Given this list of marker genes Wnt1, Snx3, Wnt2b, Wnt3, Vps35, Wnt6, Wnt4 (NCBI Gene Id 22417), Wnt5b, Wnt8b, Wnt11, Vps26a, Tmed5 (transmembrane p24 trafficking protein 5), Wnt10b, Wnt8a, Wnt7b, Wnt5a, Wnt10a, Wnt7a, Wnt2, Wnt16, Wls, Vps29, Wnt9a, Wnt3a, Wnt9b, here is a description of the gene set: WNT ligand biogenesis and trafficking Mouse Gene Set: REACTOME_WNT_LIGAND_BIOGENESIS_AND_TRAFFICKING species: Mus musculus